Given this list of marker genes Fcgr2b, H2-M3, H2-Ab1, Clec4a4, B2m, Ap3d1, Clec4a2, Tap2, H2-Eb1, H2-Ea, Clec4a3, Ctss (cathepsin S), Psme2, Traf6, H2-K1, Lgmn, H2-T23 (NCBI Gene Id 15040), Ctse, Fcgr3, Cd74, Cd1d1, Cd1d2, Ifi30, H2-Ob, H2-Oa, Psme1, H2-DMa, Mpeg1, Tapbp, Unc93b1, Mr1, Fcer1g, Pikfyve, Ap3b1, H2-Eb2, Mfsd6, H2-DMb2, H2-DMb1, Fcgr1, H2-Aa, here is a description of the gene set: Mouse Gene Set: GOBP_ANTIGEN_PROCESSING_AND_PRESENTATION_OF_EXOGENOUS_ANTIGEN The process in which an antigen-presenting cell expresses antigen (peptide or lipid) of exogenous origin on its cell surface in association with an MHC protein complex. studied in species Mus musculus